The following is a description of a gene set: Human Gene Set: HP_DECREASED_CIRCULATING_ADENOSYLCOBALAMIN_CONCENTRATION The concentration of adenosylcobalam in the blood circulation is below the lower limit of normal. Adenosylcobalamin is one of the active forms of vitamin B12. species: Homo sapiens Decreased circulating adenosylcobalamin concentration, and this is the list of marker genes: LMBRD1, MMAB, MMADHC, MMAA, MMACHC, ABCD4, PRDX1